Given this list of marker genes MCM8, ZSWIM7, KISS1R, DHX37, WT1, SOHLH1, C14orf39 (chromosome 14 open reading frame 39), CYP17A1, ESR2, CYP11A1 (cytochrome P450 family 11 subfamily A member 1), GCNA, STAG3, HFM1, SRY, SOX9 (SRY-box transcription factor 9), NSMCE2, HROB, FIGLA, PPP2R3C, MRPS22, MSH4, NR5A1, XRCC2, AR, FOXL2, SYCP2L, FGD1, NR0B1, CLPP, FANCM, VAMP7, DIAPH2, MAP3K1, POR, BMPR1B, SPIDR, CYB5A, WWOX (WW domain containing oxidoreductase), PSMC3IP, GDF9, FSHB, GATA4, ZFPM2, here is a description of the gene set: Human Gene Set: HP_ELEVATED_CIRCULATING_LUTEINIZING_HORMONE_LEVEL An elevated concentration of luteinizing hormone in the blood. studied in species Homo sapiens Elevated circulating luteinizing hormone level